The following is a description of a gene set: Any process that activates or increases the frequency, rate or extent of protein maturation. Mouse Gene Set: GOBP_POSITIVE_REGULATION_OF_PROTEIN_MATURATION species: Mus musculus, and this is the list of marker genes: Meltf, Ctnnd1, Mbl2 (mannose-binding lectin (protein C) 2), Rhbdd1, Ccbe1, Hpn, Timm17a, Tnp2, Nkd2, Spon1, Gsn, Timm23, Clec3b, Plgrkt (NCBI Gene Id 73839), Bag2, Fuz, Astl, Sox4, S100a10, Cntn2, Nlrc4, Myh9, Tfr2, Eno1, Angptl8 (angiopoietin-like 8), Mmp14 (matrix metallopeptidase 14 (membrane-inserted)), Src, Anxa2, Eno1b, F12, Tnp1